The following is a description of a gene set: part of: Post NMDA receptor activation events In addition to inducing long-term potentiation (LTP), NMDA receptor-mediated activation of CaMKII leads to transcriptional changes that are implicated in LTP maintenance. CaMKII-gamma (CAMK2G) isoform is involved in nuclear shuttling of the calcium/calmodulin complex (CALM1:4xCa2+), which enables CaMKK-mediated activation of the nuclear calcium/calmodulin dependent kinase CaMKIV (CAMK4). Activated CaMKIV phosphorylates the transcription factor CREB1 and activates CREB1-mediated transcription. species: Homo sapiens Reactome Pathway: CREB1 phosphorylation through the activation of CaMKII/CaMKK/CaMKIV cascasde, and this is the list of marker genes: CAMK4, CREB1, CAMKK1, CAMK2G, CAMKK2, KPNA2, CALM1, CAMK2B